The following is a description of a gene set: studied in species Mus musculus Any process that modulates the frequency, rate or extent of cilium-dependent cell motility. Mouse Gene Set: GOBP_REGULATION_OF_CILIUM_DEPENDENT_CELL_MOTILITY, and this is the list of marker genes: Rgn, Bbs2 (Bardet-Biedl syndrome 2), Ccr6, Tppp2, Gas2l2, Tac4, Clxn, Iqcf1, Mkks, Ttll6, Catsper1, Tacr2, Or4m1, Bbs1, Bbs4, Cfap45, Tac2, Adam7, Irgc, Cfap69, Kif9, Tac1, Spinkl, Eppin, Rnase10, Tacr1, Tex101, Defb1, Wfdc6a, Wfdc6b, Anxa5, Prdm14, Defb37, Tacr3, Cfap20, Rnase9, Cfap206